Given this list of marker genes Furin, Cpe (carboxypeptidase E), Atp6ap2, Ece2, Ace2, Slc30a5, Ctsl, Scg5, Ins2, Pcsk4, Pcsk1, Chst8, Ece1, Hsp90b1, Ero1b, P4hb, Disp1, Ren1, Adam10, Pcsk1n, Enpep, Mep1a, Corin, Slc30a8, Prcp, Yipf5, Cpa3, Pcsk5, Eef1ece2, Prep, Hid1, Ace, Anpep, Pcsk2, Pcsk6, Mme, here is a description of the gene set: studied in species Mus musculus The generation of a mature peptide hormone by posttranslational processing of a prohormone. Mouse Gene Set: GOBP_PEPTIDE_HORMONE_PROCESSING